Given this list of marker genes LY6D, RBM3, ANXA2, RHOC, PDGFA, JUNB, TFF3, CPE, MKI67, ALCAM, EPS15, ATF3 (activating transcription factor 3), SPP1, COL4A1, TGIF1, TWF2, DDR1, ETS2, VIL1, SLC7A7, ECT2 (NCBI Gene Id 55710), PLSCR1, TGFA, RAB3D, TCEAL9, BTG3, LPL, SERPINB6, ID1, BLNK, ELF3, CLDN7, CCNB1, KRT18, CD63, CA2, SERPINE1, S100A11, ACOT9, KRT8, RRM2, AEBP1, TLR6, SCD, H19, IGFBP1, CCND1, BTG2, BEX1, FOS, LTB (lymphotoxin beta), CDK1, CIDEA, RBP1, here is a description of the gene set: from publication Borlak J, Meier T, Halter R, Spanel R, Spanel-Borowski K (PMID 15674348) Human Gene Set: BORLAK_LIVER_CANCER_EGF_UP Genes up-regulated in hepatocellular carcinoma (HCC) developed by transgenic mice overexpressing a secretable form of EGF in liver. species: Mus musculus Epidermal growth factor is an important mitogen for hepatocytes. Its overexpression promotes hepatocellular carcinogenesis. To identify the network of genes regulated through EGF, we investigated the liver transcriptome during various stages of hepatocarcinogenesis in EGF2B transgenic mice. Targeted overexpression of IgEGF induced distinct hepatocellular lesions and eventually solid tumours at the age of 6-8 months, as evidenced by histopathology. We used the murine MG U74Av2 oligonucleotide microarrays to identify transcript signatures in 12 tumours of small (n=5, pooled), medium (n=4) and large sizes (n=3), and compared the findings with three nontumorous transgenic livers and four control livers. Global gene expression analysis at successive stages of carcinogenesis revealed hallmarks linked to tumour size. A comparison of gene expression profiles of nontumorous transgenic liver versus control liver provided insight into the initial events predisposing liver cells to malignant transformation, and we found overexpression of c-fos, eps-15, TGIF, IGFBP1, Alcam, ets-2 and repression of Gas-1 as distinct events. Further, when gene expression profiles of small manifested tumours were compared with nontumorous transgenic liver, additional changes were obvious and included overexpression of junB, Id-1, minopontin, villin, claudin-7, RR M2, p34cdc2, cyclinD1 and cyclinB1 among others. These genes are therefore strongly associated with tumour formation. Our study provided new information on the tumour stage-dependent network of EGF-regulated genes, and we identified candidate genes linked to tumorigenes and progression of disease.